The following is a description of a gene set: Genes having at least one occurrence of the motif RNCAGCTGC in the regions spanning 4 kb centered on their transcription starting sites. This matches the TFAP4 transcription factor binding site V$AP4_Q6_01 (v7.4 TRANSFAC). studied in species Homo sapiens Human Gene Set: AP4_Q6_01, and this is the list of marker genes: TUBB2B, GRIK3, CDK5R2, HOOK1, RTKN, SMARCA1, KCNJ2, FGF12, MYO18A, TNNI2, BNC2, GIGYF2, CCND2, PSIP1, PCBP4, SVIL, ALPK2, CCL27, RTL9, TPPP3, RBFOX1, WDR81, CCNE2, NADK2, DALRD3, GGNBP2, USP54, CREB3L1, RGS8, STIM1, FGF17, NDNF, EYA1, SYTL2, WNT6, ANK1, RBMS3, CLEC14A, MIR22HG (MIR22 host gene), DLG2, HID1, DMD, CDH6, SEZ6, HPCA, CCDC177 (NCBI Gene Id 56936), KCNMB3, RXRG, HSPB6, OR10J1, ETV1, CD72, SHOX2, ANXA8, SOX12 (SRY-box transcription factor 12), CBFA2T3, RNF121, ZSWIM8, TRIM8, BEST3 (NCBI Gene Id 84821), NANOS1, TUBB4A, EFNA1, ASB5, SORBS1, H2AC7, HSD3B7, MYLK, CCDC191, MAP3K13, HES6, UBE2D3, PAICS, CADPS, SPOP, MLLT11, CNTN2, BRD4, TUBA4B, E2F1, BRINP1, FGF13, ZMIZ1, MYH3, TAFAZZIN, KLHL40, DCAF17, PPP3CB, TNNT2, GRK5, SPATS1, LNX1, YWHAZ, GRIN2B, MOSPD1, FAM98A, NDUFAF3, MEF2D, TUBA4A, TMEM109, MLIP, KDM2A, BTBD3, RIN1, CLDN15, PDGFB, CHRD, CLVS1, RUFY1, RAB3A, PPP3CA, TGFB3, MYPN, WBP1L, WNT10A, MASP1, ITPR3, MYCBP, ZNF668, SH3BP1, LURAP1L, POLD4, RORC, ZNF385A, NOL4, TRIM46, ZMAT3, EIF4ENIF1, ACTB, SYNRG, CADM2, GFI1, NHLH2, HMGN2, LINC01089, NOTCH1, GABPB2, TMOD4 (NCBI Gene Id 29765), QTRT2, MLYCD, KNCN, CSMD3, USF1, DLL4, RPA3, ADGRL3, GPR37L1, SYT6, ORAI3, HOXA3, MSS51 (MSS51 mitochondrial translational activator), RASGEF1A, H2BC3, BACH1, APOBEC2, PTPN7, MCAM (melanoma cell adhesion molecule), S100A8, TRPC4, AGBL5, SOX2, SUMO2, ATF7IP, IGF1R, KCNQ5, PRKCG, WNT2B, KLK13, IKZF2 (IKAROS family zinc finger 2), TMEM184A, GRIN2D, VWA5A, NEURL1, RAB5B, ERF, STX17, CDKN1B, GPR162, LGALS1, PNMA1, BARX2, CLIP1, PTH1R, GNB3, RNF213, PPP1R17, THPO, RAPSN, EPHB2, ISL1, PRKCB, TGIF1, ALK, PAX1, NAGLU, HYAL2, SPG21, TFAP4, NDST4, ARHGEF2, DES, PLPP7 (NCBI Gene Id 84906), RSRC1, JPT1, RASL12, NEXN-AS1, ZNF593, TRIT1, PREX2, NOSIP, ZRANB1, METTL8, FNDC5, TNNC2, ACVR1, AICDA, H3C3, CKM, MBNL2, HJV, NDUFA4L2, DVL3, FRMPD1, KCNS3, CELF3, PROSER3, KIRREL2, HOXC12, YTHDF2, DRP2, FITM1, H3C4, NUMBL, KLF13, ACTA1, GOLPH3L, CHRNG, PRMT6, MYCN, MYO7A, ABR, SPOCK2, CSF1R, MYC, CDC42SE1, PRRG2, VEGFA, KCNN2, RGS12, OR2L13, ZNF646, GAS7, PPAT, MPPED2, BCL2L2, PSD, ZMYND8